The following is a description of a gene set: Any process that modulates the frequency, rate or extent of smooth muscle cell-matrix adhesion. Mouse Gene Set: GOBP_REGULATION_OF_SMOOTH_MUSCLE_CELL_MATRIX_ADHESION studied in species Mus musculus, and this is the list of marker genes: Serpine1, Plau, Efemp2, Apod, Pcsk5